The following is a description of a gene set: Mouse Gene Set: REACTOME_MET_ACTIVATES_PTK2_SIGNALING MET activates PTK2 signaling studied in species Mus musculus, and this is the list of marker genes: Col3a1, Col5a2, Itga2, Lama4, Col11a1, Itgb1, Hgf, Col1a2 (collagen, type I, alpha 2), Src, Megf6, Col5a3, Col1a1, Ptk2, Col5a1, Col11a2, Met, Itga3, Fn1, Col2a1